The following is a description of a gene set: Human Gene Set: REACTOME_STRAND_ASYNCHRONOUS_MITOCHONDRIAL_DNA_REPLICATION studied in species Homo sapiens Strand-asynchronous mitochondrial DNA replication, and this is the list of marker genes: LIG3, RNASEH1 (ribonuclease H1), POLG2, POLG, SSBP1, MGME1, POLRMT, TWNK, EXOG, TOP3A